Given this list of marker genes Plxdc2, Cadm2, Id2, Snx4, Tmem132b, Reg1, Atad1, Cttnbp2nl, Agl, Tmtc1 (transmembrane and tetratricopeptide repeat containing 1), Syndig1, Clock, Gucy1a2, Stag2, Tnfaip8, Tada2b, Brip1, Mtfr1, Nudt4, Sh3kbp1, Bdnf, Cavin2, Pxk, Fut9, Usp29, Asb7, Zfp820, Dpp4, Klhl38, Map3k20, Gm15114, Txlng, Fnip1, Arid4b, Slc25a51, Luzp4, Erbb4, Gm15080, Gja8, Slc30a4, Ncoa2 (nuclear receptor coactivator 2), Gm15097, Oscp1, Muc15, Wdfy2, Trim59, Kif21b, Nlrp1a, Scfd1, Them7, Smg1, Fbxo30, Tnfrsf11b, Bet1, Capza2 (NCBI Gene Id 76913), Mtor, Gmfb, Dennd6a, Tspan12, Tor1aip2, Setx, Specc1, Pank3, Scai, Ptpdc1, Vps35 (NCBI Gene Id 65114), Nsun6, Cbfb, Clstn1, Zswim5, Plaat1, Zfp616, Pdik1l, Cd2ap, Plxna2, Nfat5, Crebrf, Gm94, Marchf5, Pde5a, Fgf7, Slitrk6, Pex7, Pgam1, Fbxl17, B230219D22Rik, Srxn1, Klhl24, Syap1, Taok1, Ppargc1a, Itch, Sntb2, Dnal1, Dock4, U2surp, Hectd2, Btaf1, Cpeb2, Neurod1, Zfp39, Bhlhe22, Pdxdc1, Ric8a, Gorab, Odf2l, Fam120b, Zfp780b, Cd47, Katnbl1, Zfp235, Adipor1, Flg2, Sri, Mef2a, Itga11, Ccn4, Slc22a5, Zfp202, Ott (NCBI Gene Id 18422), Fam120c, Hnrnpa3, Cops3, Zbtb6, Tmod1, Zfp36l1, Tsc22d2, Naaladl2, Nqo2, Akain1, Api5, Scyl3, Gm15091, Slc5a12, Rnf38, Apol11b, Dcun1d4, Mtf1 (metal response element binding transcription factor 1), Camk2n1, Rab13, Spata31d1c, Clxn, Gfpt1, Gm15127, Ppp2ca, Glcci1, Nos1, Gpc5, Tk2, Zfp654, Slc7a14, Car12, Stk38, Tubb2a, Nufip2, Olfm3, Ipo11, Man2a1, A630073D07Rik, Cyp1b1, Cyfip2, Zbtb2, Gtf2a1, Mid1, Arhgap32, Klhdc8a, Il6 (NCBI Gene Id 16193), Bcl2l11, Tmed1, Parg (NCBI Gene Id 26430), Arhgap42, Gm15085, Spic, Zfp24, Cmpk1, Apol10a, Pus10, Tns4, Gm15093, Hyal6, Serinc1, Cdx4, Mmgt1, Xrn1, Gria4, Prune2 (prune homolog 2), Kpna4, Lpcat2, Cacnb4, Phf20l1, Pigr, here is a description of the gene set: species: Mus musculus Mouse Gene Set: MIR_12178_3P Genes predicted to be targets of miRBase v22 microRNA mmu_miR_12178_3p in miRDB v6.0 with MirTarget v4 prediction scores > 80 (high confidence targets). from publication Chen Y, Wang X (PMID 31504780)